The following is a description of a gene set: species: Homo sapiens Optic nerve glioma Human Gene Set: HP_OPTIC_NERVE_GLIOMA A glioma originating in the optic nerve or optic chiasm., and this is the list of marker genes: IFNG, TSC1, TSC2, NF1, SPRED1